The following is a description of a gene set: studied in species Homo sapiens Concentration of hemoglobin in the blood circulation above the upper limit of normal. Increased circulating hemoglobin concentration Human Gene Set: HP_INCREASED_CIRCULATING_HEMOGLOBIN_CONCENTRATION, and this is the list of marker genes: KCNN4, VHL, EPAS1, HBA1, SLC4A1, EPO, SH2B3, HBA2 (NCBI Gene Id 3040), EPOR, PIEZO1 (piezo type mechanosensitive ion channel component 1 (Er blood group)), JAK2, HBB, BPGM, EGLN1